Given this list of marker genes PLEKHA4, RUBCNL, SNX12, VPS13B, SNX21, DENND1A, BBS5 (Bardet-Biedl syndrome 5), SH3PXD2A, PARD3, OBSCN, PLEK2, LANCL2, PLA2G4E, WDR45B, PLEKHA5, ZFYVE28, PHLDA3, ATG2A, DAB2IP, SESTD1, SNX4, SH3PXD2B, SNX13, SAP30L, NCF4, WIPI2, HIP1, SNX19, SNX3, SNX20, PLCZ1, ZFYVE1, ZFYVE19, WASHC2C, PLA2G4A, ZFYVE26 (NCBI Gene Id 338378), SNX27, WDR45, TECPR1, PLEKHF1, WIPI1, SNX24, ATG2B (NCBI Gene Id 55102), KIF16B, VPS36, RBSN (rabenosyn, RAB effector), JPH2, RUFY4, here is a description of the gene set: Human Gene Set: GOMF_PHOSPHATIDYLINOSITOL_3_PHOSPHATE_BINDING studied in species Homo sapiens Binding to phosphatidylinositol-3-phosphate, a derivative of phosphatidylinositol in which the inositol ring is phosphorylated at the 3' position.